Given this list of marker genes HNRNPM, MIR3074, FMNL2, SRSF10, HMOX1, ADAMTSL4-AS1, SLC7A6, SHOC2, LMNB2, FRG1, RAB34, RFT1, MIR30B, SEC24A, CAP1, MIR15B, SH3BGRL3, GOLGA7, SLC1A4, MIR133A1, MIR133A2, DNAJB1, MIR30C1 (NCBI Gene Id 407031), MAP3K8 (NCBI Gene Id 8040), TUBA1A, TMEM109, RAB5C, TMED3, SFXN1 (sideroflexin 1), TNFAIP2, POM121, ZEB1, DCAF7, ARCN1, RDH10, MIR124-3, TNFSF9, MIR30E, ADPGK, YWHAQ, THBS1, RHOG, BRPF3, CEBPB, ARID4B, PRPF40A, TYMS, BCL6, ANAPC1, ADAR, TRAM1, ANPEP, ATP2A2, NELFCD, ACP2, AP3D1, LPL, PKM, ANXA2, CDCP1, TPM3, LAMTOR3, SLC7A11, FADS1 (fatty acid desaturase 1), IFRD1, MAPK14, TUSC2, MIR29B1, UNC93B1, RTN4, MIR200C, MRPL20, MIR378A, GYS1, MIR133B, IDH1, TXNRD1, MIR375, MIR34A, MIR29B2, SLC25A1, TXN2, MIR124-2, GNAI2, ATP6V0A1, ACAA2, RAB6A, PPIF (NCBI Gene Id 10105), MIR30A, WDFY1, CDK6, PHC2, CDK5RAP3, MIR29C, ATP6V1F, CDIPT, MTHFD2, MIR370, CDK5RAP1, MIR127, ARHGDIA, ATP6V0E1, MIR1-2, CHORDC1 (cysteine and histidine rich domain containing 1), SNX6, MIR200B, MRC2, CTNNB1, MIR200A, TBCA, BCL2, GAK, TMED10, PTPA, G6PD, CAPG, MPDU1, C1orf56, HMGA1, MCL1, SPTLC1, CA12, USP1, PDLIM5, PPIB, MIR16-1, TMEM43, VPS39, ADIPOR2, SAC3D1, MIR30C2 (NCBI Gene Id 407032), CD164, PLXND1, CSRP1, CORO1C, POLE4, MIR1-1, SCYL1, MIR16-2, PRSS21, POLR2C, WDR11, SERPINE2, GNA13, MIRLET7B, MATR3, PNP, CTSC, PISD, SNAP23, PTRH1, DDX5, KCNN4 (NCBI Gene Id 3783), ARF4, IGF2R, MIR30D, here is a description of the gene set: miR-targeted genes in leukocytes studied in species Homo sapiens Human Gene Set: WP_MIRTARGETED_GENES_IN_LEUKOCYTES